Given this list of marker genes Adgrv1, Bst1, Gucy1a1, Tkfc, Adcy8, Nherf4, Raf1, Calm2, Gucy2d, Gucy2g, Adcy9, Guca1a, Rnaset2a, Gnas, Calm1, Gnaz, Guca1b, Grm7, Rnaset2b, Adcy1, Gnai1, Rgs2, Adcy2, Adcy4, Guca2a, Npr1, Guca2b, Adcy10 (NCBI Gene Id 73777), Npr2, Cd38, Gucy2e, Gucy1b1, Gucy2c, Calm3, Mocs1, Gucy2f, Gucy1b2, Adcy5, Adcy3, Ncs1, Gucy1a2, Adcy6, Adcy7, here is a description of the gene set: Mouse Gene Set: GOMF_PHOSPHORUS_OXYGEN_LYASE_ACTIVITY studied in species Mus musculus Catalysis of the cleavage of a phosphorus-oxygen bond by other means than by hydrolysis or oxidation, or conversely adding a group to a double bond.